Given this list of marker genes DCHS1, RAB11FIP5, TFAP4, RBPJ, SYN3, MT3, HNRNPA2B1, PRSS16, HPX, TIMP1 (TIMP metallopeptidase inhibitor 1), FOSL2, ATF2, OAT, CD163, TFAP2C, YTHDC1, HK3, IL1R1, PLIN2, IL7R, ANKRD46, ZNF638, G0S2, ARMC8, SERPINE1, SRSF9, RNGTT, MIR22HG, SEC61G, BCL2A1, SLC27A2, PGM1, PIK3C3, CCSER2, CETN2, LBR, IFNA16, MMP7, NUP153 (nucleoporin 153), SLC6A8, CYP2B7P, CAPN2, CAPZA2, FAF2, MT1A, MAOA, KIF5C, MTCL1, CLK1, CXCL8, GMPS, SPRY2, PEX19, OTUD4 (OTU deubiquitinase 4), PAX6 (paired box 6), CCR1, PTGER3, CCDC57, CCR7, RNASE4, MT1G, DDX18, VDR, FCGR3B, RARS1, MSMB, PDIA4, HNRNPH2, P4HA2, NRIP1, CTSL, PPBPP2, GREM1, AQP9, MT1B, S100A10, MB, ADO, P4HA1, ADM, KDM3B, PLP2, FCGR3A, POLR2D, HBEGF, MRC1, ZNF292, SLC30A1, RNFT2, CLCN4, SLC20A1, PLAUR, IL1RN, ATXN3, BAAT, OSBPL8, MDFIC, SLC9A6, MORF4L2, WNK1, ANPEP, MSC, TFEC, MCM5, LTN1, CLPTM1, USP12, DDX11, BTG1, PFKFB1, KYNU, LAMP3, ARL4C, ATP1B2, PAM, CHD8, TLX2, PELP1, MT1F, EMD, CASP5, MPZL1, RAI14, ADGRL1, HNF1A, OXSR1, DDX17, TCF12, HSPA6, BAZ1A, TIPARP, HYOU1, MISP, MT1X, DNAH7, MYL6B, FUT6, VNN2, SLC12A4, BTBD3, ICAM3, GLUL, TGM2 (transglutaminase 2), VCAN, GDI2, MAGEA1, GGPS1, SSRP1, MT1H, ZNF451, H2AZ2, ATP5PB, PTPN9, GALNT18, PF4, CDH5, ATP6V1C1, PLOD2, ZC3H11A, TUBB, HMOX1, TDG, SH3BP5, BRINP1, ORC4, TAF12, KTN1, LSM3, XCL2, ZFC3H1, ZNF148, TSC22D2 (NCBI Gene Id 9819), TCP1, DAAM1, TRIP12, HCAR3, PTGER2, WSCD1, CAPN7, HK2, GTF2A1, SEL1L3, CSNK1A1, SLC2A3, MPHOSPH8 (NCBI Gene Id 54737), ADCY8, CYP1B1, UCN, TRIM33, LILRA4, ADAM8 (NCBI Gene Id 101), KIFC3, PKP4, DVL3, SEMA3C, GUCA1B, CD1C, GOLGA8A, ALDH1B1, here is a description of the gene set: Human Gene Set: GSE360_L_DONOVANI_VS_B_MALAYI_HIGH_DOSE_MAC_UP Monocyte-derived dendritic cells (DC) and macrophages (MΦ) generated in vitro from the same individual blood donors were exposed to five different pathogens, and gene expression profiles were assessed by microarray analysis. Responses to Mycobacterium tuberculosis and to phylogenetically distinct protozoan (Leishmania major, L. donovani, Toxoplasma gondii) and helminth (Brugia malayi) parasites were examined, each of which produces chronic infections in humans yet vary considerably in the nature of the immune responses they trigger. studied in species Homo sapiens Genes up-regulated in comparison of macrophages exposed to L. donovani versus macrophages exposed to 50 worms/well B. malayi. from publication Chaussabel D, Semnani RT, McDowell MA, Sacks D, Sher A, Nutman TB (PMID 12663451)